Given this list of marker genes BMP4, TGFB1, TRIM71, TIAL1, TRUB1, ZFP36, PUM2, DGCR8, FMR1, FXR1, RIPK1 (receptor interacting serine/threonine kinase 1), PUM1, here is a description of the gene set: Any process that increases the frequency, rate or extent of the inactivation of gene expression by a posttranscriptional mechanism. Human Gene Set: GOBP_POSITIVE_REGULATION_OF_POST_TRANSCRIPTIONAL_GENE_SILENCING studied in species Homo sapiens